Given this list of marker genes Ido1, Th, Thap4, Hpd, Qdpr, Tyrp1, Oca2, Gstz1, Kmo, Qprt (NCBI Gene Id 67375), Tph2, Gcdh, Iyd, Nadsyn1, Acmsd, Hgd, Afmid, Pcbd1, Ftcd, Kynu, Il4i1, Haao, Tph1, Ido2, Cyp2d22, Amdhd1, Dct, Mthfd1, Pcbd2, Nmnat2, Mthfd2l, Pah, Ttc36, Tdo2, Hdc, Hal, Uroc1, Hpdl, Park7, Slc45a2, Tat, Spr, Atp7a, Fah, here is a description of the gene set: Mouse Gene Set: GOBP_AROMATIC_AMINO_ACID_METABOLIC_PROCESS studied in species Mus musculus The chemical reactions and pathways involving aromatic amino acid family, amino acids with aromatic ring (phenylalanine, tyrosine, tryptophan).